The following is a description of a gene set: studied in species Homo sapiens The orderly movement of a cell that will reside in the hindbrain. Human Gene Set: GOBP_CELL_MIGRATION_IN_HINDBRAIN, and this is the list of marker genes: PLXNA2, LEF1, PHOX2B, ARL13B, POU4F1, ATP1B2, FLNA, CEND1, EPHB1, RERE, ITGB1, NHLH2, CTNNA2, DAB1, TTBK2, SEMA4C, EPHB2